The following is a description of a gene set: studied in species Mus musculus Mouse Gene Set: GOBP_G_PROTEIN_COUPLED_RECEPTOR_SIGNALING_PATHWAY_COUPLED_TO_CGMP_NUCLEOTIDE_SECOND_MESSENGER The series of molecular signals generated as a consequence of a G protein-coupled receptor binding to its physiological ligand, followed by activation of guanylyl cyclase (GC) activity and a subsequent increase in the concentration of cyclic GMP (cGMP)., and this is the list of marker genes: Agtr2, Fzd2, Gkap1, Gnat1, Gnat2, Nos2